The following is a description of a gene set: species: Homo sapiens Human Gene Set: GOBP_DNA_METABOLIC_PROCESS Any cellular metabolic process involving deoxyribonucleic acid. This is one of the two main types of nucleic acid, consisting of a long, unbranched macromolecule formed from one, or more commonly, two, strands of linked deoxyribonucleotides., and this is the list of marker genes: NHP2, NFRKB, RMI2, ZBTB38, NABP1, NEIL1, HELQ, RBX1, PMS2, FANCD2, MSH4, YEATS4, KHDC3L, TDP2, SMARCD2, ALKBH3, RBBP8, NIBAN2, CDK9, C11orf54, TAOK3, HMBOX1 (NCBI Gene Id 79618), RAD54B, ENPP7, SENP3, RFWD3, EXOSC5, NME1 (NCBI Gene Id 7794), RAD9B, SIN3A, NAT10, TNF, TK1, MCM2, SET, USP1, RAD50, MGMT, HNRNPD, CLCF1, DPF2, NTHL1, PDGFRB, GAR1, RAD51C, DCAF1, MAPK15, TICRR, FBXO5, TOP3B, GCNA, UBE2NL, RNF212B, CDT1, EME1, TAF5L, MMS19 (MMS19 homolog, cytosolic iron-sulfur assembly component), GGN, OBI1, DNAJC2, HMGA1, HDAC8, LONP1, TP53, NDFIP1, CDK1, DNTT, KASH5, BABAM1, APOBEC3C, NUDT15, PTPRC, FANCF, TOM1L1, POLI, HSP90AA1, RAD52, NFIX, RECQL5, ANKRD17, PARP2, FBXO6, POLD1, CHD1L (chromodomain helicase DNA binding protein 1 like), NEK2, MCM5, PARK7, RAD23A, RTF2, POGZ, NEIL2, CACYBP, TWNK, NPAS2, USP7, CCT5, USP43, PRKDC, NEK7, FOXM1, NUDT1, FAAP20, KDM2A, CENPX, APTX, USP9X, CSNK2A1, APOBEC1, TNFSF13, XRCC1, CUL4B, NSMCE3, USP22, FANCG, EXOSC4, EP400, RHNO1, PRKCG, RFC3, BCL11B (BCL11 transcription factor B), SPIDR, SIRT6, BCL7B, RIF1, FBXW7, SHLD1, IL7R, TBX21, ACTR2, H1-7 (H1.7 linker histone), SH2B1, POLG2, FAM111A, JMY, NBN, PARP4, PMS2P1, NONO, CCNB1IP1, POLN, PSME4, CIDEA, POT1, OTUB1, DMC1, AKTIP, PPP4R2, CREBBP, SMG1, DICER1, FAM111B, TAF6L, VEGFA, OTUD4, SMARCAL1, HNRNPC, CGAS, RAD51B, INIP, TTF1, PMS2P5, FUS, NME3, NPPC, RUVBL1, MRGBP, BIVM, KIF22, RNASEH2A, SPIRE1, PRKCD, RAD21L1, EMSY, FAM168A, TCF7L2, TWIST1, HINFP, LEF1, HNRNPU, BCL6, CCT6A, GTF2H2C (NCBI Gene Id 728340), RIOX1, TTF2, HMCES, H1-0, POLRMT, PCYT1A, TRAIP, RAD51AP1, PRMT1, UPF1 (UPF1 RNA helicase and ATPase), EXOG (exo/endonuclease G), ZBTB48 (zinc finger and BTB domain containing 48), CNTD1, RPA3, ASTE1, TINF2, SETX, TAF5, SSBP1, SMARCA5, UBE2A, EHMT2, ARID1A, HLTF, EXD2, ANKRD31, REV3L, ORC1, SPDYA, PDS5B, BARD1, BOD1L1, REC114, TDRD3, CIZ1, SMARCA2, DNASE1L2, CCT2, NABP2, ATF1, DCP2, MORF4L1, BRCC3, IFFO1, UBE2B, SANBR, WDR33, MAGEF1, IL10, KLF4, MDC1, MACROH2A1, CDC45, DDX1, TNKS, RPS3, MEN1, APAF1, FMN2, TOP2B, SUMO1, RAD17, DNASE1L3 (deoxyribonuclease 1L3), TRRAP, ACTL6B, ERCC5, TP53BP1, RRM2B, TENT4A, MCMDC2, TAF10, RNF169, CDKN1A, KAT2B, ADRA2A, NVL, TCP1, HELB, TCF3, FTO (NCBI Gene Id 79068), TEX15, MPND, APEX1, HUS1, XAB2, SMPD3, TERB1, HDGFL2, GIN1, PRMT6, SMCHD1, SLC30A9, SMOC2, TOP6BL, UIMC1, ENSG00000274276, SUB1, NYNRIN, SLFN11, ERCC6L, POLA2, SUPT16H, H1-1, CTBP1-DT, BAX, RAD23B, CDK2, C1orf146, DBF4B, ZRANB3, A1CF, ENY2, ATXN3, TONSL, GNL3L, CCT8, CECR2, ZSCAN4, MCM10, TET2, SMARCD1, NFIA, PARP10, TFRC, FANCM, ATRIP, CDK7, POLE3, SMARCB1 (SWI/SNF related, matrix associated, actin dependent regulator of chromatin, subfamily b, member 1), DNAJA3 (NCBI Gene Id 94389), TIGAR, TOP1, GTPBP4 (NCBI Gene Id 23560), EYA1, AP5S1, NOP53, ISG20, MEIOC, ESCO1, PRKCQ, CBX8, WDR18, PLD4, MND1, GNL3, FGFR1, KIN, NT5M, PHF10, PPP4C, PPP5C, TFDP1, POLR2I, PARP3, PARN, STOX1, CSNK1E, GZMA, DCTPP1, PELI1, STUB1, EGFR, CDC25A, REXO2, MAD2L2 (mitotic arrest deficient 2 like 2), UBR5, AICDA, ORC5, RFC5, HDAC10, YY1, PTTG1, TTC5, TADA1, KPNA1, ZNF827, APOBEC3H, KAT2A, EPC1, RTEL1, CDCA5, SPATA22, PMS2P6, CDK2AP1, RAD21, ABRAXAS1, BRD8, ACTR5, MSH6, DNASE2B, PIAS4, BABAM2, NSMCE4A, RMI1, PAXIP1, DPF1, SMC5, HNRNPA2B1, APEX2, MMS22L, CINP, ENDOG, MAPK3, TFPT, PIF1, PARG, MEI4, PPP1R10, CTC1, PLD3, XRCC6, NPM1 (NCBI Gene Id 4869, nucleophosmin 1), ORC3, GRWD1, MTA1, ETAA1, SETMAR, REV1, NSD2, PRKD2, ZFYVE26, MARCHF6-DT, APOBEC3B, FGF10, MBD4, TAF2, XNDC1N (NCBI Gene Id 100133315), BRPF3, MAPK1, NAP1L1 (NCBI Gene Id 64165), POLB (NCBI Gene Id 5423), RNF212, SYNCRIP, MCMBP, FAN1, HMGB1, NSMCE2, SETD7, EREG, STN1, MARF1, FGFR4, RAD9A, POLG, KRBA2 (KRAB-A domain containing 2), UCN, JADE2, ERCC8, TAOK1, TAF9, CDKN2D, NFIB, CCNA2, INO80E, CCT7, BRME1, RNF8, FH, CENPS, H1-6, NIPBL, C1QBP, KDM4D (lysine demethylase 4D), UCHL5, RAG1, TEX19, RNF138, TERC, IHO1, TET3, DMAP1, H1-9P, SWAP70, MPG, POLD2, MAP3K4, DKC1, MCM3, LRWD1, SYCP1, MSH3, ERCC6L2, NHEJ1, ELOF1, ZNF668, VPS72, RADX, TGFB1, CDC14B, NUGGC, GTF2H1, CETN2, PMS1 (PMS1 homolog 1, mismatch repair system component), APOBEC3D, DCLRE1C, PRIMPOL, SUPV3L1, TAF6, MEAF6, ING4, GLI2, CSNK2A2, FBXO4, GTF2H2, DTX3L, DNASE2, INO80C, TNP1, DNASE1L1, GADD45A, LIG3, CD40LG, C14orf39, KMT5A, PPP4R3B, RNF111, NUDT16L1, BATF, SSRP1, POLL, INO80B (INO80 complex subunit B), ATXN7L3, TERB2 (telomere repeat binding bouquet formation protein 2), PSMC3IP, PDGFA, MSH2, AGER, EXO1, RNASEH2B, SHLD3, PTMS, HTR2A, RNASEH1, UBE2V2, PAXX, SUPT7L, FANCI, PRDM9, MCIDAS, SLX4, TAF12, SHPRH, TATDN1, HCRT, PTGES3, SKP2, NOC3L, E4F1, PARP1, MCM6, LMNA, XPC, BCL7A, ATXN7 (NCBI Gene Id 6314), WRN, AURKB, RNF126, UBE2W, SETD2, SIRT1, N4BP2, WAS, CDC6, BRIP1, TP73, ING5, CIB1, SENP2, NOX4, CCN2, RNASEH2C, CHRNA4, TNFSF4, SMARCC2, TERF1, RCHY1, DBF4, SUPT20H, CHAF1B (chromatin assembly factor 1 subunit B), TIMELESS, HUWE1, GTF2H2C_2, ATR, MYC, CHTF8, TOP3A, MC1R, MUS81, KAT7, CLSPN, UBE2D3, RAD54L, OGG1, DACH1, RAD1, IL6, KMT5C (NCBI Gene Id 84787), PPP1CA (protein phosphatase 1 catalytic subunit alpha), KAT5, CCNE2, FGF2, PNKP, TNKS1BP1, USP47, SMARCE1, HSF1, ANKLE1, H1-4, GDF2, TREX2, CCR6, ADIPOQ, KCNK2, PTK6, DSCC1, POLE4, NSMCE1, PDGFB, SFR1, FIGNL1, H1-8, ASCC3, POLH, APOBEC3G, DDB2, RPA1, POLE, CYREN, NEURL4, DTL, SDE2, INTS3, MCM8, PARP9, CTNNB1, ARID2, ERCC4, MLH1, FANCE, SFPQ, AKT1, SPIRE2, SHLD2, ERCC1, RAD51D, NFIC, MCM4, ACVRL1, SUPT6H, SAMHD1, THAP9, APOBEC3F, ALKBH1, HMGB2 (NCBI Gene Id 3148), TIPIN, ZMPSTE24, TDG, UBE2T, GINS3, XRCC4, HMGN1, TEN1, SF3B3, GTF2H4, HGF, EYA4, SRC, SMC3, MCRS1, CDC7, H2AX, MORF4L2, DUSP1, WRAP53, ACTR8, CHTF18, FBH1, STRA8 (NCBI Gene Id 346673), UBQLN4, BAZ1A, ESCO2, TENT4B, NUCKS1, S100A11, MRNIP, SMC6, CHD4, IL4, MNAT1, IER3, MYO18A (NCBI Gene Id 9799), MGME1, HROB, XPA, NFKBIZ, EID3, ZMYND8, RAG2 (recombination activating 2), SPHK1, CHEK1, TRIP13, CDKN1B, POLQ, NOP10 (NCBI Gene Id 55505), VCPIP1, POLA1, PURA, SLC15A4, PRPF19, CHAF1A, ATAD5, USP37, MCM9, ORC2, UBE2U, AXIN2, MAP2K7, RFC2, CCT4, ORC4, ZBTB7A, BRCA2, EXOSC6, BRD7, ADPRS, FAAP100, ZGRF1, SMUG1, PBRM1, DDB1, PRIM2, WEE1, TRIM28, STK19, TEP1, SMG6, ATM, SPO11, CARM1, POLE2 (NCBI Gene Id 5427), CEBPG, DOT1L, DUT, AP5Z1, GTF2H3, EPC2 (NCBI Gene Id 96643), PPP4R3C, ANKRD1, WIZ, ARID1B, SHOC1, ZSWIM7, ZNF830, MIR221, E2F8, NEIL3 (nei like DNA glycosylase 3), SF3B5, UBE2N, ZNF365, CCT3, HMGB3, CCNE1 (NCBI Gene Id 898), CCDC117, FANCL, TEX264, MPV17, WAPL, APLF, EXOSC3, TAF4, BLM, SIRT7, PLK1, RUVBL2, PWWP3A, CEP164, TERT, CUL4A, CAMSAP3, ERCC2, H1-5, DTD1, GMNC, WDR48, ACD, SEM1, DPF3 (NCBI Gene Id 8110), LIG4, CNBP, UVSSA, H1-3, FOXL2 (forkhead box L2), TERF2IP, HFM1, USP44, SMARCA4, HORMAD1, CDADC1, ZBTB1, LOX, PKIB, AUNIP (NCBI Gene Id 79000), DYNLL1, EXO5, PGBD5, DCLRE1A, SLX1A, RNF168 (ring finger protein 168), PCNA, DHX9, CD28, XRCC5, JADE3, SWSAP1, USP45, YLPM1, FANCC, TNKS2 (NCBI Gene Id 94771), H2AC25, CENPF, HSF2BP, TDP1, PARPBP, HTATSF1, STAT6, RBBP4, ALKBH2 (NCBI Gene Id 121642), ASCC2, CDC5L, KLHDC3, METTL4, DHX36, SGF29, MEIOB, XRCC2, DYRK1B, BACH1, DNASE1, PSMD14, PPP4R3A, EXOSC10, RBMS1, INO80, HPF1, TBRG1, UFL1, TOP2A, HNRNPA1, TADA3 (NCBI Gene Id 10474), XRCC3, ZPR1, SLF2, CSNK2A3, SMARCC1, GINS4, GLRX2, BTG2, SMARCD3, DNA2, FEN1, RGCC, FAAP24, FMR1, ABL1, GINS2, MSH5, PAGR1, SMG5, BRCA1, MAJIN, IL2, HERC2, POLDIP2, USP28, GTF2H5, RECQL, TADA2B, RAD51, GATA5, TSPYL2, ASF1A, RAN, XRN1, SPRTN, TRIP12, SESN2, RBBP7, USP10, RNF113A, PML, FAF1, SUV39H1, PINX1, AEN, HUS1B, LRRC34, EYA3, CRY2, PDS5A, ERCC6, ING3, EME2, PCLAF, TMEM161A, VPS54, DONSON, NPM2 (NCBI Gene Id 286056), KCTD13, NMNAT1, RPA4, RAD18, FANCB, TERF2, TET1 (tet methylcytosine dioxygenase 1), RFC4, RRM1, GLI1, PHB1, HMGA2, CBS (cystathionine beta-synthase), USP51, UBR2, PMS2P3, NT5E, SYCE3, ASCC1, MUTYH, SCAND3, KMT5B, SP100, POLK, OOEP, TK2, BANF1, IL27RA (NCBI Gene Id 9466), TEX12, TEFM, FANCA, E2F7, TYMS, KPNA2, NAF1, CDC34, DFFA, ID3, EYA2, APOBEC3A, MLH3, TOP1MT, VCP, PALB2 (partner and localizer of BRCA2), ATP23, CHRAC1, KDM1A, SLF1, UBE2V1, FIRRM, TAF7, TNFAIP1, MRE11, ACTL6A, MBTD1, LIG1, RECQL4 (RecQ like helicase 4), WDHD1, HNRNPAB, MCM7, DDX11, TOPBP1, DEK, H1-10, EEPD1, TEX11, INO80D, GEN1, COMMD1, PRIM1, JADE1, LIN9, NASP, POLD4, ZCWPW1, WRNIP1 (WRN helicase interacting protein 1), RBBP6, MAPKAPK5, SUPT3H, SLX1B, RFC1, BCL7C, UNG, ENDOV, DFFB, HSP90AB1, HSPD1, FOXP3, GMNN, REC8, ERCC3, KLHL15, ORC6, TREX1, LTO1, REXO4, POLM (NCBI Gene Id 27434), DCLRE1B, TFIP11 (tuftelin interacting protein 11), FZR1, RPA2, CD40, POLD3, H1-2, SMARCAD1, ACTB, BCCIP, SMC1A (NCBI Gene Id 8243), GINS1, USP3, UHRF1, ATRX, CHEK2, SWI5, UVRAG